Given this list of marker genes NOTCH2NLA, SEH1L, NOL4, CCDC24, RBP3, DLGAP4, FBRS, TOM1L1, DPYSL2, CORO1A, KMT2E, PATL1, CACNA2D3, IFT80, KCP, SHISA6, CD247, YWHAE, NDRG2, LOXL1, WDR13, RARA, GREM1, KMT2D, INPP4A, ZFP36L1, XRCC6, DHRS3, PTMA, POU2AF1, ZNF532, HYAL1, ARMH4, EIF5A, HOXB1, JUND, LINC03040, PDP2, UBE2B, PRKD2, GNAS, RHOG (NCBI Gene Id 391), TEX2, DDR1 (NCBI Gene Id 780), GNB2, TAOK1, MORF4L2, PHOX2B, MEF2C, KIF1C, STX4, SEZ6, PACSIN3 (NCBI Gene Id 51165), PLA2G3, SSTR3, SREBF2, PTCHD1, NTN4, NOTCH2, BAZ2A, POU4F2, FOXP2, CPA4, ELOVL5, GFAP, UNC13D, FGF12, OSBPL7, ATP2B2, INCA1, CD2AP, NRGN, ZFYVE1, HS6ST2, CHRM3, CEBPB, RAB33A, SIK3, PLAG1, ADGRB3, ATXN7L1, KTN1, SMC4, RCOR2, SPI1 (Spi-1 proto-oncogene), NF1, BCL6B, HOXB8, here is a description of the gene set: species: Homo sapiens Genes having at least one occurrence of the motif KATCACCCCAC in the regions spanning 4 kb centered on their transcription starting sites. This matches the SREBF1 transcription factor binding site V$SREBP1_02 (v7.4 TRANSFAC). Human Gene Set: SREBP1_02